Given this list of marker genes RAP1A (RAP1A, member of RAS oncogene family), MAP2K1, TMEM108, VPS26B, GPC4, KIF2C, GHSR, DAG1, GPC6 (glypican 6), CACNA2D2 (NCBI Gene Id 9254), OLFM1, IQSEC2, NETO2, ADAM10, GABARAP, OGT, TRAF6, EPB41L3, HRAS, here is a description of the gene set: Human Gene Set: GOBP_REGULATION_OF_NEUROTRANSMITTER_RECEPTOR_LOCALIZATION_TO_POSTSYNAPTIC_SPECIALIZATION_MEMBRANE studied in species Homo sapiens Any process that modulates the frequency, rate or extent of neurotransmitter receptor localization to postsynaptic specialization membrane.